The following is a description of a gene set: Abnormal rib morphology Human Gene Set: HP_ABNORMAL_RIB_MORPHOLOGY An anomaly of the rib. studied in species Homo sapiens, and this is the list of marker genes: SMAD4, GLI3, GALNS, RSPO2, TMCO1, ESCO2, SCARF2, SNRPB, VDR, POR, B3GAT3, ATP6V1B2, CFAP410, IFT57, MYF6, WDR35, RUNX2, COL10A1, SRP54, GABRD, AKT1, RRAS2, WNT3 (NCBI Gene Id 7473), MYH3, SEC24D, ANK1, NOG, WNT1, TOR1A, KMT2A, MAN2B1, PTDSS1, PIGG, COL11A1, FRAS1, USP18, DNMT3A, WNT4, ARSK, ROR2, CDC45, LRP5, PPP3CA, CDT1, TGIF1, ATP7A, STIL, RPS26, INPPL1, ADA, NEK9, LIFR, RIPPLY2, HSPG2, GNPTAB, AFF3, LRP4, FBN1, MUSK, GNS, TENT5A, KIAA0586, CENPJ, ARSL, TRPV6, AMER1, PTCH1, IFT172, TNFSF11, PTPN11, MAF, LAMA5, AIFM1, INTU, GAS1, PDPN, EXT1, FGFR3, MEOX1, WASHC5, SLC34A1, PRKG2, PTH1R, FGFRL1, LMOD3, HES7, VANGL1, ALG12, JAG1, IL1RN, SIX6, GRIP1, IKBKG, CTNS, GPX4, KIAA0753, GNPNAT1, TAPT1, CYP27B1, HNRNPR, CASZ1, OBSL1, DYNC2H1, TBCK, DISP1 (NCBI Gene Id 84976), SOX9, GDF11, CHRND, SNX10, GDF6, CCDC22, LUZP1, SLC35D1, MAMLD1, CYP2R1, TBCE, KYNU, GLI2, IFT80, PRDM16, EZH2, BRD4 (bromodomain containing 4), SP7 (Sp7 transcription factor), DYNC2LI1, SCUBE3 (NCBI Gene Id 222663), B4GAT1, CEP152, TOMM7, SIX3, TNFRSF11A, PRKCZ, NEK1, TCIRG1, KLHL40, IFT122, MAP3K7, ACTA1, CRTAP, HNF1B, DNM2, NEB, CPLX1, ERMARD, ORC6, COL1A1, SH2B1, NKX3-2, TBX5, FUZ, BANF1, CDC6, HOXD13, GUSB, PAICS, RYR1, CPLANE1, CSPP1, SF3B4, RNU12, ARSB, PHEX, GPC3, SCN4A, POLR3A, P4HB, DYM, TTC21B, CHD7, MEG3, ABCD4, BGN, TRIP11, KCNAB2, MGP, CHST3, DACT1, SBDS, MATN3, SKI, TBX4 (T-box transcription factor 4), MTM1, PLCB3, ZIC2, NXN, RBM8A, COG1, TMEM53, IDUA, RMRP, LBR, PLOD1, OCRL, SUFU, EVC2, WDR19, NODAL, FREM2, DHCR24, LFNG, NELFA, HGSNAT, MYF5, SOX2, DYNC2I1, GATA6, EXOC6B, CCN2, SRCAP, DLL1, RTTN, EBP, ATR, TRPV4 (transient receptor potential cation channel subfamily V member 4), ZMPSTE24, UBE4B, RERE, TBX6, ABCC9, SLC26A2, COL2A1, KLHL41, SMO, DPYSL5, DDR2, CHD6, EXT2, HDAC6, PPIB, FLNA, PAM16, NFASC, NALCN, MTX2, VPS35L, ALDH1A2, FERMT1, WNK3, ORC4, RNU4ATAC (RNA, U4atac small nuclear), SF3B2, SGSH, CRIPTO, SETBP1, RPS19, SERPINH1, IFT43, WNT7A, FLI1, DLK1, PCYT1A, NSDHL, UBA1, EFL1, BIN1, FOXF1, CTBP1 (C-terminal binding protein 1), NIPBL (NCBI Gene Id 25836), LETM1, SALL1, B3GALT6, GDF3, ALPL, SON, MESP2, CDON, ODC1, CUL7, APC, DYNC2I2, COL1A2, GPC4, EVC, CHRNA1, IFT140, PORCN, LMNA, SPEN, CHRM3, FIG4 (NCBI Gene Id 9896), FAM111A, GMNN, NUP88, VAC14, PAX3 (NCBI Gene Id 5077), TBC1D24, DONSON, BMP2, IRF6, ADAMTS10, CCDC8, C2CD3, DDRGK1, COMP, GLB1, RECQL4, SLC34A3, MMP23B, DYNLT2B, FGF8, LMX1B, DHCR7, PDGFRB, CHRNG, SEMA3E, IDS, CA2, SHH, DNAJC21 (NCBI Gene Id 134218), RTL1, PUF60, KCNJ8, ANKRD11, MTMR14, GLE1, TFE3, NAGLU, TGFBR1, NSD2, SLC26A1, ACTB, PRIM1, SOST, XYLT1 (NCBI Gene Id 64131), ORC1, BMPER, IFT81, CEP120, COL11A2, IHH, FLNB, PTCH2, MMP13, P3H1, CLCN7, FOXH1, DLL3, CREB3L1